The following is a description of a gene set: Human Gene Set: CAGTGTT_MIR141_MIR200A species: Homo sapiens Genes having at least one occurence of the motif CAGTGTT in their 3' untranslated region. The motif represents putative target (that is, seed match) of human mature miRNAs hsa-miR-141 and hsa-miR-200a (v7.1 miRBase)., and this is the list of marker genes: STAT5B, DDX5 (DEAD-box helicase 5), BAHD1, TBL1XR1, NR2C2, DIXDC1, JUN, PDS5B, SIM2, CCDC177, SIPA1L2, PTGES3, GRB2, PPP2R2A, RAB38, HDAC4, KIF3A, RBMS1, TP53INP1, RBM33 (RNA binding motif protein 33), H2AZ1, ERRFI1, STX2, ACOT7, FRMD6, SOX11, RPH3AL, CDV3, BAP1, TRHDE, APBB2, ANP32E, CTNNA1, CSF3, TSHZ3, EPN1, FAM168B, IRS2, SCN2B, CDC14A, RUNX1, SON, TAF12, ZCCHC24, CDK17, MTSS1 (MTSS I-BAR domain containing 1), HOXB5, TNRC6B (trinucleotide repeat containing adaptor 6B), SLC1A1, NMNAT2, CLASP2 (NCBI Gene Id 440948), LENG8, MYH10, GLRX, NRXN1, STRN, PITPNB, TFRC, KIAA0408, XKR7, PAPPA, ATXN1, KHDRBS2 (NCBI Gene Id 202559), CYP26B1, SLC39A9, GPC2, RBM7, PRELID3B (NCBI Gene Id 51012), MBD5, ZCCHC3, PTPRG, YWHAG, SPAG9, SPRYD3, MBNL1, LRRC8A (NCBI Gene Id 56262), OSBPL11, SLC20A1, DMWD, STAT5A, CHP1, ELF2, HIPK1, YTHDC1, TGFB2, CCNE2, PCNX2, PDCD4, DOLPP1, LYPLA1, PGRMC2, TCERG1, STEAP2, PRKACB, NSD2, CSNK2A1, LUC7L3, CALCR, RNFT1, DRD2, SNX27, HNRNPF, MECP2, PEX5, PTP4A1, SEMA6A, STXBP1, TMEM135, SYT4, RTN4RL1, C16orf87, DMXL1, PHLPP2, PDZD2, GPM6B, CFAP20DC, VSIG8, ATF5, PPT2, ATXN7, FOXA1, MYRIP, PLAGL2, TSC1, PLAG1, DLC1, AK4, RTF1, TRAM1 (translocation associated membrane protein 1), RARB, YTHDF2, BACE1, ELAVL2, SERF2, STXBP5, ANKFY1, MAP2K4, ZBTB18, HLF, SOX5, C1orf21, SOBP, CSNK1G3, STK35, KALRN, OLIG3 (oligodendrocyte transcription factor 3), EVI5L, FGFR2, FRMD4A, WAPL, INO80D, VPS26B, TTR, MIB1, WDFY3, HOXB4, SFPQ, RNF44, GRIN3A, CAMSAP2, AMPD2, EPHA7, MARCHF7, LHX6, WIPF1, SEPTIN7, ESRRG, SLC16A7, E2F3, SIAH1, SEC11A, C2orf42, NAMPT, ELMOD1, RMND5A, ZNF644, TCF12, WDR26, PPP2CA (NCBI Gene Id 5515), PCDH8, SLC6A9, IGF2BP2, DEK, MMP16, SRC, BICD2, CELF6, RABGAP1, USP9X, CALU, LPP, KIF1C, SLC17A6, NUDCD1, TTBK2, CNP, PCGF3, MINDY3, CSNK1A1, YAF2, ATP2A2, LRATD2, ATP6V1B2, ARHGEF18, FBXL2, KLHL18 (kelch like family member 18), RAP2C, PHYHIPL, ACVR2A, DIP2B, ATAT1, KCNJ2, SLC25A3, POU4F1, CREBRF, DNAJC13, JAZF1, EPHA2, THRB, PAFAH1B2, CDK13, CXCL12, CUL3, CTNND2, MAP7D1, DCUN1D3, IRF2BPL, CDC42BPB, ATP1B1, PITX2, ST3GAL3, ASTN1, AGFG2, NFASC, CHD9, RAD23B, ATP6V1A, TIAL1, HMG20A, DR1, SNAP91, ATL1, ZEB2, PCDH9, MOB3B, EXOC5, STAT4, YPEL5, PHLPP1, OGT, FKBP5, WDR44, TENT5C, IKZF5, MDM1, OLFM1, STIMATE, NRP1, QKI, CPD, TFAP2C, ARPC5, SP4 (Sp4 transcription factor), SUPT6H, UBE3A, TNKS2, ITSN1, PPM1E, FUS, WSB1, ASXL1, PPP1R15B, CD47, MED13L, B3GNT2, NRP2, FOXN3, CBL, RNF145, BHLHE40, SIRT1, TULP4, KPNA3, ZFR, ERC2, TTYH2, CDC25A, BRD3, TMEFF1, CEP120, HOXC13, TNS3, PSEN1, CNR1, MDGA1, SIK1, FOXP1, SLC23A2, MYT1L, HIC2, DUSP3, ZNF609, TOP1, BMAL1, ACACA, MTPN, HOXA11, YTHDF3 (YTH N6-methyladenosine RNA binding protein F3), GATA6, TM9SF4